Given this list of marker genes Plagl2, Tgif2, Rufy1, Tnfrsf12a, Alkbh7, Glis2, Dok4, Mmaa, Gdf15, Ptprs, Zfp319, Ogn, Dst, Klhl24, Cnih4, Ifrd1, Syne3, Osr1, Rhobtb3, Ccn2, Mrgprf, Dusp1, Rhof, Dnajc17, Trim16, Sqstm1, Ndfip1, Gjb4, Slc25a28, Trmt61a, Irf2bpl, Car12, Tubb6, Plcd3, Pmm2, Ido2, Mapk13, Stk11, Fign, Polr3h, Rfx1, Palmd, Ahctf1, Skil, Cavin4, F11r, Cyb5rl, Tpm2, Bhlhe40 (NCBI Gene Id 20893), Rpl19, Ccnd1, Iffo2, Ftl1, Znrf2, Zfp438, Loxl2 (NCBI Gene Id 94352), Psca, Ubc, Dmpk, Card10, Slc35d1, Cers2, Hoxd12, Hif1an, Tctn1, Cacnb1, Acadm, Grik5, Uck1, Fubp1, Prss8, Cpa1, Fscn1, Hoxd13, Serinc5, Rilpl2, Pdgfd, Mpv17l2, Oxnad1, Efna1, Rhod, 1700013G24Rik, Rpl10a, Tspan9, Lctl, Fth1, Map2k5, Blnk, Faim2, Dusp6, Ddx5, Sptbn1 (NCBI Gene Id 268394), S100a3, Fgf18, Clec9a (C-type lectin domain family 9, member a), Ctsb (NCBI Gene Id 210034), Rnd3, Gde1, Nvl, Dusp14, Psmd12, Mllt6 (myeloid/lymphoid or mixed-lineage leukemia; translocated to, 6), Add3 (NCBI Gene Id 98171), Ppm1l, Wnt10b, Msln, Lamc1, Spart, Dpp9, Gjb5, Fn1, Atxn2 (NCBI Gene Id 320857), Junb, Slurp1, Capns1, Rhoq, Calu (NCBI Gene Id 319452), Smad6, Pitpnm2 (NCBI Gene Id 19679), Avpi1, Mast2, Anxa9, Shpk, Pdlim4, Dmp1, Pkm, Syt8, Kitl, Chka, Hook2, Matn3, Coq10b, Aox1, Ctbp2, G6pdx, Sirt6, Pitpnc1, Ube2c, Loxl1, Arhgef19, Dhrs3 (NCBI Gene Id 20148), Osbpl2, Aoc2, Pidd1, Rpl13a, Pcnx4, Thrsp, Wwtr1, Ndufb8, Lrp1, Rcbtb2, Usp44, Ampd2, Cp, Nid2, Nck2, Coa3, Aldh3a1, Fam20a, Pex2, Hoxa13, Gpr146, Col1a1, Ramp2 (receptor (calcitonin) activity modifying protein 2, NCBI Gene Id 54649), Plekhb1, Jrk, Fbln2, H1f10, Fcho2, Btn1a1, Furin, Sntb2, S100a8, Slc25a4, Pdlim7, Pkn1, Ereg, Tnfrsf9, Baalc, Tnfrsf11b, Sgk1, Rpl3l, Gsr, Rock2, Clpp, Gprc5a (NCBI Gene Id 353241), Inppl1, Tgfb3, Rras, Nid1, Midn, Prss22, Aebp1, Fstl1, Hgfac, Rarb (retinoic acid receptor, beta), Hmga1, Top2b, Ndufs8, Lsp1, Zbp1, Ubxn8, Ap2a2, Pitx1, Slc25a51, Vegfa, Pyurf, Cfl2, Esd, Cyp2d22 (cytochrome P450, family 2, subfamily d, polypeptide 22), Ado, Rarg, Metrn, Calr, Pdlim2, Sat1, Ephb2, Hoxa10, Chmp1a, Nrp1, S100a4, Efcab2, Rex1bd, Cttn, Mmp2, Ddx24, Uspl1, Gas8, Gdpd5, Cdkn2d, Capn5, Pik3r2, Osbpl3, Scaf1, Il34, Tns2, Kif5b, Fgfr2, D830044D21Rik, Nr1d1, Inf2, Ifi27, Crabp2, Ctns (NCBI Gene Id 83429), Ppl, Rab30, Abcb8, Arf2, Pigt, Omp, Gas2, Tm4sf1, Pgpep1, Sh3bp1, Med9, Spsb2, Tmem179, Idh3b, Dnm1, Zfp474, Lnx2, Pla2g6, Pttg1ip, Resf1, Rnf139, Nrn1, Agpat1, Otud5, Wnt1, Snrnp35, Bsg, Plscr2, Fcna, Cep95, Spata33, Dpysl3, Shc1, Cntd1, Ccdc124, Ckb (NCBI Gene Id 12709), Tirap, Sstr4 (NCBI Gene Id 20608), Il1rn, Ltbp1, Ankrd24, Sec1, Rilp, Nudt6, Rlim, Ndufa4 (Ndufa4, mitochondrial complex associated), Sulf1, Dedd, Tpst2, Slc39a13, Rnf5, Stub1, Clcf1, Tcp11l2, Ltbp3, Itgbl1, C1qtnf1, Anxa1, Dph5, Hpdl, Cebpb, Rhobtb2, Eps8l2, Pick1, H2bc14, Dbndd1, Olfml2a, Tagln2, Nbl1, Prss30, Cpsf4, Itih2, Slc25a24, Arsa, Pcolce, Clnk, Tnfsf13, Timp3, Wnk4, Inmt, Fam107b, Rrp1, Mbnl1, Tyk2 (tyrosine kinase 2), Dusp4, Src, Bcl2l11, Gabarapl1, Rin2, Sun2, Parp3, Nupr1, Ctsd, Rhoc, Rb1cc1, Mbd6, Ccp110, Ndufb10, Aqp5, Park7, Tcirg1, Echdc3, Dennd2b, Usp6nl, Ddit3, Dgat1, Tnrc18, H1f2, Zfp574, Tmem127, Csdc2, Mrpl34, Phyhd1, Lipe, Mrpl37, St3gal3, Me3, Evx2, Als2cl, Prx, Hhatl (NCBI Gene Id 74770), Traf3ip2, Atp11a, Nek2, Dmwd, Yap1 (NCBI Gene Id 22601), Emp1, here is a description of the gene set: Genes with DNA sequences bound by RARG in MEF cells (embryonic fibroblast). Mouse Gene Set: DELACROIX_RARG_BOUND_MEF species: Mus musculus from publication Delacroix L, Moutier E, Altobelli G, Legras S, Poch O, Choukrallah MA, Bertin I, Jost B, Davidson I (PMID 19884340) All-trans retinoic acid (RA) induces transforming growth factor beta (TGF-beta)-dependent autocrine growth of mouse embryonic fibroblasts (MEFs). We have used chromatin immunoprecipitation to map 354 RA receptor (RAR) binding loci in MEFs, most of which were similarly occupied by the RAR alpha and RAR gamma receptors. Only a subset of the genes associated with these loci are regulated by RA, among which are several critical components of the TGF-beta pathway. We also show RAR binding to a novel series of target genes involved in cell cycle regulation, transformation, and metastasis, suggesting new pathways by which RA may regulate proliferation and cancer. Few of the RAR binding loci contained consensus direct-repeat (DR)-type elements. The majority comprised either degenerate DRs or no identifiable DRs but anomalously spaced half sites. Furthermore, we identify 462 RAR target loci in embryonic stem (ES) cells and show that their occupancy is cell type specific. Our results also show that differences in the chromatin landscape regulate the accessibility of a subset of more than 700 identified loci to RARs, thus modulating the repertoire of target genes that can be regulated and the biological effects of RA.